Given this list of marker genes RBMY1F, SF3A3, SYF2, SNRPD2, RBM28, AKAP17A, HSPA8, ZMAT5, SNRPGP15, DHX38, CWC15, SF3A2, HNRNPA2B1, SF3B1, SNRNP70, AAR2, PRPF40B, SLU7, HNRNPA1L3 (heterogeneous nuclear ribonucleoprotein A1 like 3), SF3B6, SNRPC, HNRNPK, DHX8, RBMX2 (NCBI Gene Id 51634), LSM8, CWC22, LSM6 (NCBI Gene Id 730962), PRKRIP1, HNRNPA1 (heterogeneous nuclear ribonucleoprotein A1), RBMXL1, YJU2, LSM7, SNIP1, PPIL2, CCDC12, GPKOW, DDX39B (NCBI Gene Id 7919), DDX23, BUD31 (NCBI Gene Id 8896), LSM3, SRSF1, ALYREF, DDX41, HNRNPH3, RBM5, WAC, ZNF830, GCFC2, PRPF38B, CLNS1A, SNRPB2, SREK1, PABPC1, DDX42, HNRNPA1L2, SNW1, RBM8A, IVNS1ABP, CTNNBL1, CIRBP, LSM2, PPIL1, SCNM1, EFTUD2, ARMC7 (NCBI Gene Id 79637), CASC3, DDX46, CWF19L2, RBM3, HNRNPM, DHX40, HNRNPH1, SMNDC1, ZRSR2, SRRM1, SNRNP48, XAB2, CRNKL1, RNF113A, PDCD7, SNRPE, PHF5A, CDC5L, U2AF2, RBMY1E, HNRNPU, EIF4A3, PPP1R8, GPATCH1, AQR, PPWD1, RBMY1A1, RNF113B, TRA2A, DNAJC17, ESS2, SF1, PRPF39, CDC40, ZCCHC8, SNRPG, C9orf78, BCAS2, DHX35, PNN, TFIP11, SF3B5, HNRNPA3, HNRNPR, DQX1, SNRPD1, YBX1 (NCBI Gene Id 7806), RALY, HNRNPF, PRPF18, CWF19L1, SUGP1, MFAP1, U2AF1L4, PRPF31, PPIE (NCBI Gene Id 10450), RBMX, BUD13, SNRNP200, PPIL3 (peptidylprolyl isomerase like 3), SF3B4, FRG1 (NCBI Gene Id 2483), ZMAT2, ZCRB1, LUC7L, TXNL4A, TSSC4, MTREX, RBM41, SF3B2, ADAR, KHDC4, SNRNP40, HNRNPC, PRPF40A, TXNL4B, TRA2B, RHEB, ISY1, USP39, NCL, U2AF1, LGALS3, RBM48, CWC25, PRP4K, IK, SNU13, PRPF38A, SF3A1, RBM22, SART1, LUC7L3, DHX16, UPF1, SNRNP35, ZRSR2P1, PRPF19, RNPC3, SNRPD3, SNRPN, PRPF4, SYNCRIP (NCBI Gene Id 10492), RBMY1D, DHX15, PPIH, HTATSF1 (HIV-1 Tat specific factor 1), WBP4, SNRPF, LUC7L2, LSM5, CWC27, TTF2, PRPF3, SNRPB, DHX32, RBMY1J, DDX5, CRIPT, GEMIN2, LSM4, YJU2B, RBM44, SF3B3, CACTIN, API5, MAGOHB, RBMY1B, WDR83, PTBP2, SMU1, PRPF8, MAGOH, PLRG1, SNRNP25, SRRM2, SNRPA, RBM17, SNRPA1, HNRNPDL, PRPF6, here is a description of the gene set: Human Gene Set: GOCC_SPLICEOSOMAL_COMPLEX Any of a series of ribonucleoprotein complexes that contain snRNA(s) and small nuclear ribonucleoproteins (snRNPs), and are formed sequentially during the spliceosomal splicing of one or more substrate RNAs, and which also contain the RNA substrate(s) from the initial target RNAs of splicing, the splicing intermediate RNA(s), to the final RNA products. During cis-splicing, the initial target RNA is a single, contiguous RNA transcript, whether mRNA, snoRNA, etc., and the released products are a spliced RNA and an excised intron, generally as a lariat structure. During trans-splicing, there are two initial substrate RNAs, the spliced leader RNA and a pre-mRNA. species: Homo sapiens